Given this list of marker genes GTPBP1, EEF1D, EEF1B2, TSFM, ABTB1, EEF1A2, EEF1G, EEF1A1, TUFM, EFL1, EIF5A2, GFM1, HBS1L, EEF2, GFM2, EEFSEC, GTPBP2, EIF5AL1, EEF1A1P5 (NCBI Gene Id 1921), EIF5A, here is a description of the gene set: Functions in chain elongation during polypeptide synthesis at the ribosome. Human Gene Set: GOMF_TRANSLATION_ELONGATION_FACTOR_ACTIVITY species: Homo sapiens